The following is a description of a gene set: Human Gene Set: GAO_LARGE_INTESTINE_ADULT_CI_MESENCHYMAL_CELLS from publication Gao S, Yan L, Wang R, Li J, Yong J, Zhou X, Wei Y, Wu X, Wang X, Fan X, Yan J, Zhi X, Gao Y, Guo H, Jin X, Wang W, Mao Y, Wang F, Wen L, Fu W, Ge H, Qiao J, Tang F (PMID 29802404) studied in species Homo sapiens, and this is the list of marker genes: TUBG2, STAT4, PDE4B (NCBI Gene Id 5142), CYP4F29P, ARHGAP6, NCF1, CD300A, PPP1R18, VPREB3, INPP5D, BNIP3, CLECL1P, CYTOR, CYBB (NCBI Gene Id 1536), TET1, GRK5, BASP1, LCP1, IL10RB-DT, CCR10, PAQR6, CREB3L2, CERCAM, NCF4, RUNX3, HCLS1, EMB, ELMO1 (engulfment and cell motility 1), NR3C1, GNG2, SAMSN1, IL27RA, KCNN3, CD52, APOBEC3G, CD79A, PPM1K, MEF2C, IFFO2, C16orf74, XCL2, SUSD3, ATP8B2, LRRC8C, CDK14, SASH3, LILRB1, CORO1A, ADAM8, TAGAP, LSP1, ABCB9, ITGA8, FCGR2B, CABLES1, SYNGR1, DUSP5, TNFRSF17, CLEC2B, CHST15, ASB2, RNF122, CD79B, HVCN1, SELPLG, P2RY10, CLIP4, OAS2, SPINK2, SEPTIN1, MAP4K1, IKZF1, SFMBT2, CHST11, APBB1IP, PRDM1, KCNAB2, WAS, CD19, NFATC1, ANKRD20A11P, MEI1, FLT3LG, WNT10A, PARVG, PHGDH, HLA-DPA1, HLA-DOB, IRAG2, ANXA6, LINC01480, LGALS1, MYO5A (myosin VA), IRF5, MZB1, TPST2, CD7, MYL2, NUGGC, CD53, CD3E, DAPP1, ANKRD36BP2, RGS1, SLC7A5, GNG7, PCBP1-AS1, OSBPL3, PLEKHO1, DOK3, S100A4 (NCBI Gene Id 6275), HOMER3, TNFRSF13B, TPSAB1, CD27, BMF, SLC12A4, PARVB, RHOH, LINC00582, DENND6B, SEC14L1 (SEC14 like lipid binding 1), TMC8, ICAM4, BTN2A2, RASGRP3, RHEX, MYO1G, CYTH4, ST3GAL6, LINC02384, GIMAP4, CIBAR2, WIPF1, GYPC, RGCC, RAB34, EVI2B (ecotropic viral integration site 2B), MIAT, LAMA5, FICD, TMEM156 (NCBI Gene Id 80008), SRGN, LINC00309, SLC2A3, BLK, PLAAT3, DOCK2, SLFN11, EMP3 (epithelial membrane protein 3 (MAM blood group)), FCRL5, STX11, PECAM1, GPR65, GPSM3, LINC02362, ST3GAL1 (ST3 beta-galactoside alpha-2,3-sialyltransferase 1), NLRP1, RUNX2, DOK2, CCDC102A, CD48, ST8SIA4, FCRL2, BTK, LAPTM5, A1BG, RELT, ARHGDIB, VIM, PNOC, CST7, GABRR2, IGFLR1, TRPV2, AIM2, IL23A, KLHL5 (NCBI Gene Id 54163), GPR183, FXYD5, PIK3CG, ISG20, JSRP1, DTNB, NCKAP1L, CFAP54, KIF19, TMEM45A, SP140, GLDC, SLC47A1, CEP128, ARHGAP25 (Rho GTPase activating protein 25), DOCK8, EAF2, COL18A1, CCDC88A, TRG-AS1, FER1L4, ZAP70, ITGB2, KLHL6, IGLL5, MX2, CCDC69, PTPN7 (protein tyrosine phosphatase non-receptor type 7), SPOCK2, DENND5B, NCF1C (NCBI Gene Id 654817), ZNF532, TRIB2, IL12RB1, ALOX5, ICAM1, SLC7A7, TEX14, TNFRSF18, NCF1B, MSN, IL10RA, ZEB1, GSTM2 (NCBI Gene Id 82152), GMFG, ADA2, COL24A1, LINC00996, NIBAN1, NXPE3, SCPEP1, BRSK1, FAM117A, NR4A3, IRF4, FRMD6, COL9A3 (collagen type IX alpha 3 chain), GPLD1, EVI2A, RRAGD, TNS1, PDK1, CYRIA, GLIPR1, AQP3, CSF2RB, FLI1, ITGA4, HYCC1, CAV1, TGFB1, HERC5, PGLYRP2, PRKCB, TP53INP1, LIMD2, TRPV3, SLAMF1, LAMP3, POU2F2, FCMR, CD37, BLVRA, LINC-PINT (NCBI Gene Id 648716), SNAI3, POU2AF1 (NCBI Gene Id 5450), TPSB2, SLC1A4, TCF4, HCST, TRIM69, ARHGAP30, RCSD1, IL7R, LCK, ABI3, ANKRD44, ADA, FGD2, ITGB7, RASA3, PTPRS, ACAP1, STAP1, GAMT, LY96, KCNA3, RHOQ, SYNE3, GLCCI1, LY9, NKG7, TNFRSF4, CD69, SLA, ERN1, SELENOM, TASL, LAX1, TNF, PPP1R16B, CEP85L, PAIP2B, CDKN2A, ADAM19, FGL2, COL4A4, PTPRCAP, SIT1, ALOX5AP, C1QC (complement C1q C chain), ADAM28, RASAL3, ARHGAP4, DERL3, THEMIS2, TRAF3IP3, CD2, ITGAL, P2RX5, GPR15, IL16, FYB1, AMPD1, UAP1L1, RGS19, FYN, HHEX, CIMAP1B, ZBP1, IGF1, IFNAR2, LY6E, ADGRG5, SKAP1, ARHGAP15, MANEA, PCED1B-AS1, CD3D, P2RX1, RASSF5, GOLGA8IP, CYTIP, WAKMAR2, CTSW, RAB30 (RAB30, member RAS oncogene family), SLAMF7, PTPRC, CPNE5, ZEB2, CSGALNACT2, SPAG4, ARHGAP9, MICB, BST2, SEPTIN6, TBC1D10C, RFLNB, OSR2, ENO2, ANKRD28, COQ10A, C16orf54